The following is a description of a gene set: Human Gene Set: GOBP_REGULATION_OF_BRANCHING_INVOLVED_IN_MAMMARY_GLAND_DUCT_MORPHOGENESIS species: Homo sapiens Any process that modulates the rate, frequency, or extent of branching involved in mammary gland duct morphogenesis., and this is the list of marker genes: CAV3, WNT5A, PHB2, ETV5, TGFB1